The following is a description of a gene set: Genes predicted to be targets of miRBase v22 microRNA hsa-miR-196b-3p in miRDB v6.0 with MirTarget v4 prediction scores > 80 (high confidence targets). Human Gene Set: MIR196B_3P from publication Chen Y, Wang X (PMID 31504780) studied in species Homo sapiens, and this is the list of marker genes: ANGPTL3, LRRC1, PPFIBP1 (NCBI Gene Id 8496), MCTP2, CDH7, UNC13A